Given this list of marker genes Slc39a4, Slc39a5, Fos (FBJ osteosarcoma oncogene), Tnfrsf11a (tumor necrosis factor receptor superfamily, member 11a, NFKB activator), Sp7, Ctsk, here is a description of the gene set: Mouse Gene Set: GOBP_RESPONSE_TO_ZINC_ION_STARVATION Any process that results in a change in state or activity of a cell or an organism (in terms of movement, secretion, enzyme production, gene expression, etc.) as a result of a starvation stimulus, deprivation of zinc ion. species: Mus musculus